Given this list of marker genes Mrpl55, Mrpl14, Mrpl21, Mrps7, Mrpl58, Mrps12, Mrpl53, Mrpl32, Mrps6, Mrpl13, Mrpl57, Mrpl33, Mrps35, Mrpl16 (NCBI Gene Id 94063), Mrpl11, Mrpl22, Oxa1l (oxidase assembly 1-like), Mrpl23, Mrpl2, Mrpl36, Malsu1, Mrpl17, Mrpl40, Mrpl15, Mrps33, Mrpl27, Mrps36, Mrpl34, Mrps21, Mrps17, Mrpl51, Mrpl3, Mrpl1, Mrpl54, Mrpl52, Aurkaip1 (NCBI Gene Id 66077), Mrps26, Mrpl28, Mrps18c, Mrpl47, Mrpl35, Mief1 (NCBI Gene Id 239555), Mrps16, Mrpl4, here is a description of the gene set: Reactome Pathway: Mitochondrial ribosome-associated quality control part of: Mitochondrial translation species: Mus musculus This event has been computationally inferred from an event that has been demonstrated in another species.<p>The inference is based on the homology mapping from PANTHER. Briefly, reactions for which all involved PhysicalEntities (in input, output and catalyst) have a mapped orthologue/paralogue (for complexes at least 75% of components must have a mapping) are inferred to the other species. electronically inferred by orthology from the curated human pathway